The following is a description of a gene set: from publication Pasqualucci L, Bhagat G, Jankovic M, Compagno M, Smith P, Muramatsu M, Honjo T, Morse HC 3rd, Nussenzweig MC, Dalla-Favera R (PMID 18066064) Most human B cell non-Hodgkin's lymphomas (B-NHLs) derive from germinal centers (GCs), the structure in which B cells undergo somatic hypermutation (SHM) and class switch recombination (CSR) before being selected for high-affinity antibody production. The pathogenesis of B-NHL is associated with distinct genetic lesions, including chromosomal translocations and aberrant SHM, which arise from mistakes occurring during CSR and SHM. A direct link between these DNA remodeling events and GC lymphoma development, however, has not been demonstrated. Here we have crossed three mouse models of B cell lymphoma driven by oncogenes (Myc, Bcl6 and Myc/Bcl6; refs. 5,6) with mice lacking activation-induced cytidine deaminase (AID), the enzyme required for both CSR and SHM. We show that AID deficiency prevents Bcl6-dependent, GC-derived B-NHL, but has no impact on Myc-driven, pre-GC lymphomas. Accordingly, abrogation of AID is associated with the disappearance of CSR- and SHM-mediated structural alterations. These results show that AID is required for GC-derived lymphomagenesis, supporting the notion that errors in AID-mediated antigen-receptor gene modification processes are principal contributors to the pathogenesis of human B-NHL. Genes down-regulated in post-GC, BCL6 dependent B cell non-Hodgkin's lymphoma (B-NHL) vs MYC driven pre-GC lymphoma. Mouse Gene Set: PASQUALUCCI_LYMPHOMA_BY_GC_STAGE_DN species: Mus musculus, and this is the list of marker genes: Chchd10, Lactb, Vpreb3, Pgp, Rasgrp2, Rasgrp1, Nudt19, Blvrb, Stx7, Prkacb, Trib2, Anp32e, Myo1g, Mybpc2, Pde3b, Cklf, Smim14, Rbm38, Fam43a, Ezh2, Top2b, 4930426D05Rik, Bank1, Jakmip1, Hhex, Tmem229b, Serpinb1a (serine (or cysteine) peptidase inhibitor, clade B, member 1a), Rfx7, Coro7 (NCBI Gene Id 78885), Susd3, Pum2, Id3, Fcho1, Rbm43, Nucks1 (nuclear casein kinase and cyclin-dependent kinase substrate 1), Bcl11a, Niban3, Snx2, Gpd1l, Chd1, Rdh12, Srsf1, Fryl, Tmsb10, Cpsf6, Rabep2, E2f2, Camkk2, S1pr4, Ptbp3, Cxxc5, Tnfrsf19, Gmfg, Plekha2, Nap1l1, Lcp1 (lymphocyte cytosolic protein 1), Spast, Gm13012, Acss1, Klhl24, Ankrd44, Irag2, Cnot6l, Snn, Tmem243, Arhgef18, Ptprcap, S100a10, Ube2d1, Ebf1, Frat2, Rin3, 1700097N02Rik, Stk4, Cdkn2c (cyclin dependent kinase inhibitor 2C), Cyfip2, Coro1a, Cplx2, Dek, Obi1, Cd55, Pdlim1, Gfod1, Btg1, Rnf2, Mir142hg, Uqcc5, Was, Mex3b, Ptgr3, Hnrnpdl, ENSMUSG00000141856, Snrpn, Tusc3, Arhgap15, Phc2, Smarce1, Aff3, Cd79a, Cd19, Ighd, Mknk2, Celf2, Brd3, Cpm, Sypl1, Diras2, Napsa, Sash3, Cd22, H2bc21, Ube2d3, Mterf2, Sh3bp5, Cecr2, Usp25 (NCBI Gene Id 30940), Nedd9 (NCBI Gene Id 319669), Zcchc2 (NCBI Gene Id 98679), Bach2, Ccr7, Bcat1, Fus, Itpr1 (inositol 1,4,5-trisphosphate receptor 1), Clic1, Mtpn, Rassf3, Cd24a, Prkcb, Fam111a (family with sequence similarity 111, member A), Sbk1, Klf2, Pclaf, Ets1, Wdfy4, Pde2a, Limd2, Rcsd1, Fcrla, Arhgdib, Cnn3, Sesn3, Crip1, Fh1, Cux1, Bcl7a, Cdkn2d, Zfpm1, Cotl1, Pax5, Dnah8, Ppm1e, Emb, D930048N14Rik (RIKEN cDNA D930048N14 gene), Zbtb18, Ankrd13a, Syncrip, Cd37, Dnajc9, Cpn1, Cbfb, Chst7, Gypc, Sh3kbp1, Klhl14, Cdk19 (cyclin dependent kinase 19), Sms, B3gnt5, Stag2, Btbd1, Tnfaip8, Bag2, Lsp1, Ripor2 (NCBI Gene Id 76622), Ppp1r36dn (NCBI Gene Id 100041694), Ccdc50, Tnni2, Slc25a37